The following is a description of a gene set: Reactome Pathway: Regulation of gene expression in late stage (branching morphogenesis) pancreatic bud precursor cells species: Homo sapiens part of: Regulation of beta-cell development The properties of transcriptional networks in late stage (branching morphogenesis) pancreatic bud precursor cells are inferred from the properties of well-studied networks in mouse models. In mice, committed but undifferentiated epithelial cells are organized into branching ductal structures. At a molecular level, expression of Pdx1, Nkx2.2, and Nkx6.1 is reduced while Hnf6 expression remains high. Hnf6 mediates the continued expression of Onecut3 and Hnf1 beta and epithelial cell proliferation. As expression of Ngn3 (corresponds to human NEUROG3) rises, endocrine differentiation of the epithelial cells begins., and this is the list of marker genes: KAT2B, CREBBP, SNW1, KAT2A, MAML3, ONECUT3, EP300, MAMLD1, RBPJ, HNF1B, HES1, NEUROG3, ONECUT1, MAML2, MAML1, NOTCH1